The following is a description of a gene set: Any process involved in the progression from anaphase/telophase to G1 that is associated with a conversion from high to low mitotic CDK activity. Human Gene Set: GOBP_REGULATION_OF_EXIT_FROM_MITOSIS studied in species Homo sapiens, and this is the list of marker genes: PPP1R9B, CDC14C, TGFB1, CDKN1C, UBE2C, SIRT2, CDC14A (cell division cycle 14A), KNTC1, NPM2, CDKN1B (cyclin dependent kinase inhibitor 1B), CDC23, ANLN, CDCA5, CDC14B, RGCC, ZW10, BIRC5, NEUROG1, MAD2L1BP